The following is a description of a gene set: The process whose specific outcome is the progression of an extraembryonic membrane over time, from its formation to the mature structure. Human Gene Set: GOBP_EXTRAEMBRYONIC_MEMBRANE_DEVELOPMENT studied in species Homo sapiens, and this is the list of marker genes: FZD5, DNAJB6, DNMT3L, MAP3K4, E2F7, TMED2, BMP5, TAF10, E2F8, PAXIP1, HTRA1, ASCL2, BMP7